Given this list of marker genes TNS3, RTN4, CRKL, TEK, ALS2, AUTS2, PIK3CG, FNTA, CCR7, DOK7, CRK, CCL19, KRAS, LRP4, PIK3CB, RASGRF1, CDKL5, here is a description of the gene set: studied in species Homo sapiens Any process that activates or increases the frequency, rate or extent of Rac protein signal transduction. Human Gene Set: GOBP_POSITIVE_REGULATION_OF_RAC_PROTEIN_SIGNAL_TRANSDUCTION